The following is a description of a gene set: BACKGROUND: Prostate cancer is characterized by heterogeneity in the clinical course that often does not correlate with morphologic features of the tumor. Metastasis reflects the most adverse outcome of prostate cancer, and to date there are no reliable morphologic features or serum biomarkers that can reliably predict which patients are at higher risk of developing metastatic disease. Understanding the differences in the biology of metastatic and organ confined primary tumors is essential for developing new prognostic markers and therapeutic targets. METHODS: Using Affymetrix oligonucleotide arrays, we analyzed gene expression profiles of 24 androgen-ablation resistant metastatic samples obtained from 4 patients and a previously published dataset of 64 primary prostate tumor samples. Differential gene expression was analyzed after removing potentially uninformative stromal genes, addressing the differences in cellular content between primary and metastatic tumors. RESULTS: The metastatic samples are highly heterogenous in expression; however, differential expression analysis shows that genes are upregulated and genes are downregulated at least 2 fold in every patient with metastasis. The expression profile of metastatic samples reveals changes in expression of a unique set of genes representing both the androgen ablation related pathways and other metastasis related gene networks such as cell adhesion, bone remodelling and cell cycle. The differentially expressed genes include metabolic enzymes, transcription factors such as Forkhead Box M1 (FoxM1) and cell adhesion molecules such as Osteopontin (SPP1). CONCLUSION: We hypothesize that these genes have a role in the biology of metastatic disease and that they represent potential therapeutic targets for prostate cancer. Human Gene Set: CHANDRAN_METASTASIS_TOP50_DN Top genes down-regulated in metastatic vs primary prostate cancer tumors. species: Homo sapiens from publication Chandran UR, Ma C, Dhir R, Bisceglia M, Lyons-Weiler M, Liang W, Michalopoulos G, Becich M, Monzon FA (PMID 17430594), and this is the list of marker genes: TM9SF3, CIRBP, STAT6, ANXA11, TRAPPC1, WAS, ETHE1, SFRP1, CRYBG1 (NCBI Gene Id 6763), ABI2, FOS, AGGF1, ZDHHC4, C12orf57, G3BP1, NR4A1, PHB2, POMT1, TOMM20, AHI1, IER2, INTS11, ARL5A, SORBS2, RPS27L, B3GALNT1, MAGED2, ROGDI, KCTD3, MALAT1, NT5DC1, MSRB2, CHMP4B, SELENOM, SYTL1, NOP53, CRYL1, BOC, MRC2, EFHD2, PBXIP1, APCDD1 (APC down-regulated 1), RAB34, WNT5B